The following is a description of a gene set: Mouse Gene Set: GOMF_BENZODIAZEPINE_RECEPTOR_ACTIVITY Combining with benzodiazepines, a class of drugs with hypnotic, anxiolytic, anticonvulsive, amnestic and myorelaxant properties, to initiate a change in cell activity. species: Mus musculus, and this is the list of marker genes: Gabrg3, Gabra6, Gabrg2, Gabra3, Gabra1, Gabrg1, Gabra5, Gabra2, Gabra4, Gabre, Tspo